Given this list of marker genes FITM2, ZNF263, ZNF609, VCP, DUSP2, PRADC1, PSMG4, JMJD6, ARMCX5, SKA2, BNIP1, EGR1, ATPSCKMT, NCF2, MAP2K6, EEF1AKMT2, GPR34, SULT1A1, NLRP3, CENPU, IFT74, SRSF6, DOK2, TOMM70, RAB14, SRSF2, EXOSC9, EIF3D, CLTA, MTFR1, PPFIBP1, TDRKH, SLC38A6, FEN1, ZNF697, PDGFA, NUDT9, TUT7, LYRM7, DAGLB, MRPS12, RFC5, PTGS1, TPM3, GOLIM4, TM2D1, OST4, MYCBP, PPP2CB, AIFM1, ERCC1, KCNK13, URM1, GPD1L, HPGDS, CCT6B, CASP6, CUTA, COMMD5, CLCN3, RAB4B, GMFG, SMIM29, CORO1A, IMPA2, OLFML3, OLFML2B (olfactomedin like 2B), NPM3, NAA10, TRIAP1, ADI1, MTMR14, LIAS, SERTAD1 (SERTA domain containing 1), IER2, FLVCR2, PMPCA, SLC12A9, RAB7B, ARFIP1, MLH1, CYTH4, CENPN, HCLS1, PREP, NAIP, CH25H, GLIPR1, TOP1MT, VMA21, SLC10A7, STRAP, MCM6, PDLIM2, S100A4, ALDH5A1, USP16, RBL1, SYAP1, EFTUD2, ANAPC15, PI4KB, NIBAN2, NDC1, UBE3D, CTBP2, PET100, ZNF367, PEX1, CHN2, DTWD1, PROS1, FOXRED1, MSRA, HADH, STXBP5, VPS45, CENPB, SNX4, CREB5, EGR2, TRMT10C, MBNL3, SNX8, ACAP3, COX8A, LINC00667, RASSF5, PSMC5, GTF2A2, TPRKB, UQCRH, JADE1, SLA, TSHZ3, BTBD3, ALG5, LSM7, ABHD16A, SPTSSA, SKI, INSIG1, MTREX, CCND3, MPPE1, GCNT1, TMEM64, PCSK5, SHQ1, ALDH6A1, FAM76B, FCER2, C1orf54, SLC22A18, THBD, LRRC58, ARV1, DHX40, AIG1, PCTP, ZSCAN9, RAB31, UHRF1, PAK1, U2AF1, MAGED1, PYCARD, C1QBP, ANPEP, ARHGAP9, MAGOH, NARF, SATB1, MAP7, UROS, ADAM17, TP53RK, WDR37, C2orf69, CIAO2B, FOXQ1, LSM4, ZW10, PSMD6, MED31, TMEM273, DCUN1D5, NELFCD, ZWINT, EIF2A (NCBI Gene Id 83939), POLR2L, SAMM50, ARHGDIB, ZNHIT1 (NCBI Gene Id 10467), SLC35D1, PTPN6, MRPS24, MGST2, MEF2C, here is a description of the gene set: studied in species Homo sapiens Type 1 IFNs can conditionally activate all of the signal transducers and activators of transcription molecules (STATs), including STAT4. The best-characterized signaling pathways use STAT1, however, and type 1 IFN inhibition of cell proliferation is STAT1 dependent. We report that type 1 IFNs can basally stimulate STAT1- and STAT4- dependent effects in CD8 T cells, but that CD8 T cells responding to infections of mice with lymphocytic choriomenigitis virus have elevated STAT4 and lower STAT1 expression with significant consequences for modifying the effects of type 1 IFN exposure. The phenotype was associated with preferential type 1 IFN activation of STAT4 as compared to STAT1. Stimulation through the TCR induced elevated STAT4 expression, and STAT4 was required for peak expansion of antigen-specific CD8 T cells, low STAT1 levels, and resistance to type 1 IFN-mediated inhibition of proliferation. Thus, a mechanism is discovered for regulating the consequences of type 1 IFN exposure in CD8 T cells, with STAT4 acting as a key molecule in driving optimal antigen-specific responses and overcoming STAT1-dependent inhibition of proliferation. Human Gene Set: GSE40666_UNTREATED_VS_IFNA_STIM_EFFECTOR_CD8_TCELL_90MIN_DN Genes down-regulated in CD8 T cells at day 8 after LCMV infection: untreated versus interferon alpha. from publication Gil MP, Ploquin MJ, Watford WT, Lee SH, Kim K, Wang X, Kanno Y, O'Shea JJ, Biron CA (PMID 22968462)